Given this list of marker genes IVD, BCKDK, BCKDHB, DLD, DBT, HIBCH, ECHS1, PPM1K, BCKDHA, MCCC2, MCCC1, AUH, ACAT1, here is a description of the gene set: Human Gene Set: REACTOME_DISEASES_OF_BRANCHED_CHAIN_AMINO_ACID_CATABOLISM Diseases of branched-chain amino acid catabolism species: Homo sapiens